Given this list of marker genes SAMD4A, KLF10, SPEN, RAPGEF2, RBM5, AURKA, RAB1A, USP1, RAD21, ATP2A2, XPO1 (exportin 1), KANK1, MAPK6, HMGA2, EEF1E1, CHSY1, GNE, FZD7, GNAI1, FILIP1L (filamin A interacting protein 1 like), UFL1, HMGB2, BHLHE40, ARID5B, UBE2G1, PDCD10, PHC2, DICER1, BMPR1A, CCN2, KPNA2, DDX17, THUMPD1, DUSP7, POGZ, ZBTB18, CLINT1, PPP2R5C, GATA2, SEC24B, ATP13A3, ARF6, SNRNP40, DDX3X, USP10, SLC20A2, TPST1, SIAH1, PUM1, UAP1, ZFP36, KRIT1, SMURF2, CCNB1, here is a description of the gene set: DNA damage caused by UV radiation initiates cellular recovery mechanisms, which involve activation of DNA damage response pathways, cell cycle arrest and apoptosis. To assess cellular transcriptional responses to UVC-induced DNA damage we compared time course responses of human skin fibroblasts to low and high doses of UVC radiation known to induce a transient cellular replicative arrest or apoptosis, respectively. UVC radiation elicited >3-fold changes in 460 out of 12,000 transcripts and 89% of these represented downregulated transcripts. Only 5% of the regulated genes were common to both low and high doses of radiation. Cells inflicted with a low dose of UVC exhibited transcription profiles demonstrating transient regulation followed by recovery, whereas the responses were persistent after the high dose. A detailed clustering analysis and functional classification of the targets implied regulation of biologically divergent responses and suggested involvement of transcriptional and translational machinery, inflammatory, anti-proliferative and anti-angiogenic responses. The data support the notion that UVC radiation induces prominent, dose-dependent downregulation of transcription. However, the data strongly suggest that transcriptional repression is also target gene selective. Furthermore, the results demonstrate that dose-dependent induction of cell cycle arrest and apoptosis by UVC radiation are transcriptionally highly distinct responses. Cluster d4: genes progressively down-regulated in WS1 cells (fibroblast) through 12 h after irradiation with high dose UV-C. studied in species Homo sapiens from publication Gentile M, Latonen L, Laiho M (PMID 12907719) Human Gene Set: GENTILE_UV_RESPONSE_CLUSTER_D4